Given this list of marker genes GLUD1, SLC25A22, SLC25A13, SLC25A12, GOT2, here is a description of the gene set: Mitochondrial carrier deficiency associated with shuttle disturbances Human Gene Set: WP_MITOCHONDRIAL_CARRIER_DEFICIENCY_ASSOCIATED_WITH_SHUTTLE_DISTURBANCES studied in species Homo sapiens